The following is a description of a gene set: Mouse Gene Set: GOBP_OSTEOCLAST_FUSION studied in species Mus musculus The plasma membrane fusion process that results in fusion of mononuclear osteoclasts to form a multinuclear osteoclast., and this is the list of marker genes: Cd81, Dcstamp, Cd109, Tcta, Adam8, Sh3pxd2a, Sbno2